Given this list of marker genes GPNMB, SPTSSA, TCF4, MAFB, APOE, SERPINA3, CRYAB, BBOX1, SOX4, KRT10, DSG3, here is a description of the gene set: species: Homo sapiens Nonmalignant human mammary epithelial cells (HMEC) seeded in laminin-rich extracellular matrix (lrECM) form polarized acini and, in doing so, transit from a disorganized proliferating state to an organized growth-arrested state. We hypothesized that the gene expression pattern of organized and growth-arrested HMECs would share similarities with breast tumors with good prognoses. Using Affymetrix HG-U133A microarrays, we analyzed the expression of 22,283 gene transcripts in 184 (finite life span) and HMT3522 S1 (immortal nonmalignant) HMECs on successive days after seeding in a lrECM assay. Both HMECs underwent growth arrest in G0-G1 and differentiated into polarized acini between days 5 and 7. We identified gene expression changes with the same temporal pattern in both lines and examined the expression of these genes in a previously published panel of microarray data for 295 breast cancer samples. We show that genes that are significantly lower in the organized, growth-arrested HMEC than in their proliferating counterparts can be used to classify breast cancer patients into poor and good prognosis groups with high accuracy. This study represents a novel unsupervised approach to identifying breast cancer markers that may be of use clinically. from publication Fournier MV, Martin KJ, Kenny PA, Xhaja K, Bosch I, Yaswen P, Bissell MJ (PMID 16849555) Human Gene Set: FOURNIER_ACINAR_DEVELOPMENT_LATE_UP Genes up-regulated late in HMEC cells (mammary epithelium) during acinar development in vitro.